Given this list of marker genes MAFG, CYTH3, SIPA1L1, SLC35B2, MAGT1, CXCL16, C9orf72, DIABLO, BRAF, PPCDC, ANKRD11, NUP98 (nucleoporin 98 and 96 precursor), SNPH, RNMT, MADD, TIPARP, ATP6V1C1, ELL2, CDADC1, USP47, DYNLT3, WTAP, CHMP2B, GPR65, FAM209B, ARF4, RLF, TMEM88, SEC23B, RBKS, RGS1, OXSR1, EML2, PGK2, EZH2, CDKN1A, KIFC1, SH3D21, CERK (NCBI Gene Id 64781), ETV3, CCNT1, SPTY2D1, STIP1, RBM12, FBXO28, SNIP1, ENO1, ATP1A1, IER5, DCAF1, SERP1, FKBP2, EFCAB3, APOO (apolipoprotein O), SEC22B, CTNNAL1, THAP9, METTL21A, GASK1A, CD83, TXNDC11, RALGAPA1, PIK3IP1, YPEL5, EIF1AX, ZNF16, HSPA13, ZHX2, PLEKHB2, GGT1, DENND5A, TOM1, PRR5L, SLC36A4, POLR3E, OXSM, LAMB3, SNU13, MAFF, GPATCH2L, STRAP, SYNCRIP, CREB3, EMP3, CCDC134, LACC1, TNFRSF8 (TNF receptor superfamily member 8), ATP13A3, MCM6, BZW1, PDE2A, ANKHD1, NABP1 (NCBI Gene Id 64859), GPAT4, AMPD2, KCNH2, MAP2K3, DNAJB11, TFDP1 (NCBI Gene Id 7027), TNF, SOD2, HIVEP2, EAF1, POFUT2, PIK3R5, TFG, NAPA, SNAPC1, MAP4K4, NFKBID, LDHA, GNA15, MAP3K8, AFTPH, ASCC1, P4HB, DUSP5, TFRC, CHD1, IL4R, CBX5, NFE2L2 (NCBI Gene Id 4780), CNOT2, DUSP16, TRAF3IP3, MIS18A, N4BP1, NFKBIA, FRMD4B, TPI1, CABLES2, PRKCH (NCBI Gene Id 79030), GGA1, MAPK6, THUMPD3-AS1, PHF19, IL10RA, SETD5, MAPKAPK2, PDCD4, MAPK1IP1L, RASSF5, MAFK, FBXW7, ANKRD33B, RAPGEF2, ABCF1, ZNF292 (NCBI Gene Id 23036), PTGES, CHD4, GJB6, BRPF3, TGIF2, B3GNT5, GGTLC1, LIMS3, PDE4B, EIF4A1, LRRC20, RAB8B (RAB8B, member RAS oncogene family), TNFAIP6, ARIH1, DHX36, G3BP2, TJAP1, SUB1, ZMIZ1, PDE4D, SPAG4 (NCBI Gene Id 6676), SERPINB9P1, TMEM41B (NCBI Gene Id 440026), SPHK1, HPS5, HSPA9, HMGA1, PLAUR, IL1R2, SLC43A3, SEC31A, PPP2CA, NFKBIE, TAF13, WDR1, DUSP2, CYP51A1, PSEN1, ZNF267, PNPLA8, SNX20, ANKS3, ZBTB1, KANSL3, TMEM170A, ADM, ACAA1, STX11, DNTTIP2, here is a description of the gene set: Human Gene Set: GSE37416_0H_VS_3H_F_TULARENSIS_LVS_NEUTROPHIL_DN Genes down-regulated in comparison of control polymorphonuclear leukocytes (PMN) at 0 h versus PMN treated with F. tularensis vaccine at 3 h. from publication Schwartz JT, Bandyopadhyay S, Kobayashi SD, McCracken J, Whitney AR, Deleo FR, Allen LA (PMID 22986450) species: Homo sapiens We demonstrated recently that both constitutive and FAS-triggered apoptosis of human neutrophils are profoundly impaired by Francisella tularensis, but how this is achieved is largely unknown. To test the hypothesis that changes in neutrophil gene expression contribute to this phenotype, we used human oligonucleotide microarrays to identify differentially regulated genes in cells infected with F. tularensis strain LVS compared with uninfected controls. In order to examine the effect of F. tularensis on the neutrophil transcriptome, we performed microarray expression analysis on human neutrophils treated with F. tularensis subsp. holarctica live vaccine strain (LVS).